Given this list of marker genes AGXT, CAD, GOT1L1, BHMT2, GOT2, PLOD2, SERINC5, SRR, MTRR, GGT1, HAO1, AGXT2, CPS1, PCBD1, GOT1, PHGDH, APIP, PSAT1, GLUD1, PLOD3, ASNS, NAGS, CBS, ASL, SEPHS2, OTC, GLUD2, ASS1, NOXRED1, PYCR3, PSPH, ENOPH1, ATP2B4, SERINC3, CLN3, LGSN, SHMT2 (serine hydroxymethyltransferase 2), OAT, MTR (NCBI Gene Id 4548), PYCR2, SHMT1, ALDH18A1, ADI1, PARK7, SEPHS1, CTH, BHMT (NCBI Gene Id 83323), MTHFD1, GLS2, ASNSD1, PAH, GLUL, ENSG00000274276, PYCR1, GLS, here is a description of the gene set: The chemical reactions and pathways resulting in the formation of an alpha-amino acid. Human Gene Set: GOBP_ALPHA_AMINO_ACID_BIOSYNTHETIC_PROCESS species: Homo sapiens